The following is a description of a gene set: studied in species Homo sapiens Activation of receptor-interacting serine/threonine protein (RIP) kinases RIPK1 and RIPK3 coordinate an immunogenic form of programmed cell death known as regulated necrosis or necroptosis (Upton JW et al. 2017). This form of necrosis leads to anti-viral inflammation in host through cell death-associated release of damage-associated molecular patterns (DAMPs) (Nailwal H & Ka-Ming Chan F 2019; Upton JW et al. 2017). Microbial pathogens are able to modulate host regulated necrosis through different triggers and pathways. The promotion and inhibition of host cell death vary and depend on the microbe types, virulence, and phenotypes (Upton JW et al. 2010, 2012, 2017; Jaclyn S Pearson JS et al. 2017; Petrie EJ et al. 2019; Fletcher-Etherington A et al. 2020; Nailwal H & Ka-Ming Chan F 2019; ). Reactome Pathway: Microbial modulation of RIPK1-mediated regulated necrosis part of: Defective RIPK1-mediated regulated necrosis, and this is the list of marker genes: CASP8, NS, MLKL, OPG199, UL36, RIR1, RIPK1, RIPK3, 3a